Given this list of marker genes Ctag2, Tprkb, Gon7, Ctag2l2, Osgep, Trp53rka, Ctag2l1, Lage3, Trp53rkb (NCBI Gene Id 76367), here is a description of the gene set: species: Mus musculus A protein complex involved in t6A tRNA modification. For example, in Saccharomyces cerevisiae the complex contains Bud32p, Kae1p, Gon7p, Cgi121p, and Pcc1p. Mouse Gene Set: GOCC_EKC_KEOPS_COMPLEX